The following is a description of a gene set: from publication Yang HT, Wang Y, Zhao X, Demissie E, Papoutsopoulou S, Mambole A, O'Garra A, Tomczak MF, Erdman SE, Fox JG, Ley SC, Horwitz BH (PMID 21217011) Bone marrow-derived macrophages were produced from mice lacking IL-10 alone (IL10-def) or mice lacking both IL-10 and the p50/p105 subunit of NF-kB (p50/IL10), and left unstimulated, stimulated with LPS (1 ng/ml) or stimulated with LPS and IL-10 (0.3 ng/ml). Genes up-regulated in IL10 knockout macrophages stimulated by IL10 versus NFKB1 knockout macrophages stimulated by IL10 and LPS. Human Gene Set: GSE19941_IL10_KO_VS_IL10_KO_AND_NFKBP50_KO_LPS_AND_IL10_STIM_MACROPHAGE_UP studied in species Homo sapiens, and this is the list of marker genes: TCF4 (transcription factor 4), GPATCH8, KIF1A, NXNL2, FRMD4B, DDRGK1, BTG1, FAM114A1, SALL4, STK31, SLC44A2, CSTB, CLASP2, SSX2IP, DUSP7, EPN1, PCNP (NCBI Gene Id 57092), ZCCHC12, RAB3IL1, PIK3IP1, MAP4K3, TBC1D14, VAMP7, LHFPL6, GANAB, EAF2, SLK, IHH, TSPAN14, ZNF217, STAB1, ENDOD1, FOSL2, AGTR2, SNORD89, SLC38A5, NCOR1, WDR37, TRAM2, NEXN, PWWP2B, SEMA3D, ABI3, BMP2K, MYO16, CRAT, AMZ1, KIFC3, CDC42SE1, PIK3CG, ACSL3, KLRG2, PIP4P1, MIER3, CNDP2, GPR35, FYCO1, PRSS12, CD160, GDF11, AGAP1, MBD1, PTK2, PAK1IP1, GAB2, GASK1B (golgi associated kinase 1B), PDCL3, ATP6V0A1, PDZD4, KLHDC1, MEGF8, LAMC2, ARFGEF2, UBR5, PREP, OGFRL1, SLC44A3, GPSM2, SFXN3, ZFC3H1, ACSBG1, GPR146, KCNC3, TSPAN13, MAF, WAS, LGMN, CDK13, CPZ, CWH43, CLDN19, GRAMD4 (NCBI Gene Id 23151), NCF4, NRIP3, G6PC1, EPB41L2, RCC1L, KYNU, NPR3, KCNAB2, BAHD1, ATP7A, ZNF318, PDLIM5, FAM91A1, TRIP10, FBXL12 (F-box and leucine rich repeat protein 12), EMP1, ASB7, TMEFF1, TOX2 (TOX high mobility group box family member 2), BST2, MOB3B, C1GALT1, VANGL2, GAL3ST1, KCNMB4, BCL6B, DMRT3, KCTD6, KCNK12, SGPL1, PRNP, MRPL58, CRTC3, SELPLG, SRCAP, TRPM4, PIK3R5, B4GALT1, IL4R (interleukin 4 receptor), EXOC1, SELENOM, ZSCAN10, FBXL21P, CAPN2, FBXL5, RNF146 (ring finger protein 146), USP54, CTSF, RPL10, GPR15, LMO4, MYO5A (myosin VA), GIPR, TNFRSF12A, ACVR2A (NCBI Gene Id 92), MACIR, FURIN, CCDC183, AHRR, SMAD9, COG5, COL6A3, PLTP, VDR, DMBX1, GJB4, RNASE4, REPS2, IER2, ANG, IL6ST, GAD1, PRDX6, TMEM176B, CPOX, GAMT (guanidinoacetate N-methyltransferase), TLCD4, RNF149, SLC35D1, PGS1, MYADM, RBSN, GNGT2, CDKL3, NMRK2, GPX1, CD99L2, PLEKHH2, CMAS, DDI2, KLRD1, TNK2, HBP1, PIK3R1, ZNF565, PTPRN2, PTPN12, ZSWIM4, MYOF, UCHL1, CCNL1, SMAD4, PAK2, NCMAP, GLI3, IFFO2, EREG